The following is a description of a gene set: studied in species Mus musculus Mouse Gene Set: chr14A1, and this is the list of marker genes: Gm6356, Gm8279, Rpl19-ps4, Gm3242, Gm17188, Gm3411, Gm3739, Fam107a, Gm16434, Gm3317, Slc25a5-ps, Gm3760, Csnk2a1-ps1, Gm3488, Gm26991, Gm26552, Gm10340, Gm26650, 2610318M16Rik, Gm3187, Gm3453, Gm8396, 4930521O11Rik, Gm3030, Gm8340, Gm3029, Gm3532, Gm5087, Atxn7, Gm3140, Gm3594, Gm3326, Or2t6 (olfactory receptor family 2 subfamily T member 6), Gm3264, Gm8266, Gm8206, Sntn (sentan, cilia apical structure protein), Gm3033, Gm3182, Gm3043, Gm3373, Cep15, Gm6676, Gm8108, Gm10409, Gm8323, Gm17121, Psmd6, Gm5797, Fhitos, Cdhr18, Gm3752, Gm3278, Fezf2, Gm3248, Gm26655, Gm9800, Gm3344, Or2t1, Gm17046, Kctd6, Gm2888, Gm3500, Gm8379, Gm26630, Gm10413, Gm3895, Gm3115, D830030K20Rik, Rpl21-ps4, Gm3173, Gm5795 (predicted gene 5795), Gm3149, Gm17805, Gm3636, Gm3020, Gm11100, Thoc7, Gapdhrt, Gm10128, Gm3466, Gm3755, Il3ra, Gm21103, Gm2956, Gm3667, Gm22053, Gm3348, Esd-ps, Cfap20dc, Gm17048, Gm3269, Gm8164, Gm10406, 4930455B14Rik, Slc4a7, Gm3642, Gm10338, Acox2, Gm24578, Gm6337, Gm8297, Nek10, Gm3261, Gm8416, Gm3696, Gm10408, Gm2866, Gm17045, Gm20241, Gm19018, Gm16525, Gm9603, Gm3298, Gm3138, Gm3727 (NCBI Gene Id 545011), Gm3512, Gm10410 (NCBI Gene Id 666808), Gm3685, Hmgb3-ps, Gm3005, Gm33933, Gm16440, Gm18071, Gm3252, Gm3208, Gm45521, 4930555G01Rik, Gm8237, Gm8050, Gm3275, Gm21560, Gm3091, Gm3012, Gm8246, Gm3383, Gm18077, Gm3194, Gm3339, Gm3239, Gm6734 (NCBI Gene Id 627139), 1700110I01Rik, Gm5456, Pdhb, Gm2877, Mir5124b, Gm8305, Gm26680, Gm8271, Pxk, Gm21063, Gm8483, Gm3558, Gm8281, Gm2871, Gm8324, Fhit, Rpp14, Gm3170, Mnd1-ps, Gm8374, Gm7876, Gm8265, Lamtor3l, 2610042L04Rik, Gm3637, Gm10044, Or2t35, Gm3476, Gm4904, Dnase1l3, Gm3526, Gm3164, Gm3095, Flnb, Gm3629, Gm3127, Gm8438, Gm3618, Gm3542, Gm25964, Gm8159, Gm3468, Gm2907, Gm2897, Gm3047, Synpr, Gm5457, Gm9602 (predicted gene 9602), Gm3424, Gm3084, Gm8362, Cadps, Gm2974, Gm3159, Abhd6, Gm5796, Gm17222, Fam3d, D030051J21Rik, Gm26893